Given this list of marker genes Slc7a11, Il18, Mef2c, Nod2, Ghsr, Ccl5, Clec5a, Gata1, Cxcr2, Cdkn2a, Fcer1g, Selenos, Mif, Fcgr2b, Gas6, Kitl, Apoh, St6gal1, Cd44, Nf1, Epo, Adam17, Anxa1, Stat5b, Il3, Thra, Bcl2, Ccr5 (NCBI Gene Id 235693), Snai2, Pten, Stat5a, Sirt1, Itpkb, Adipoq, Maea, Pik3cb, Hcar2, Pik3cd, Trim35, here is a description of the gene set: Any process that modulates the frequency, rate, or extent of myeloid cell apoptotic process. Mouse Gene Set: GOBP_REGULATION_OF_MYELOID_CELL_APOPTOTIC_PROCESS studied in species Mus musculus